Given this list of marker genes FYB1, HOXA11, MPL, SLC7A7, GNA14, ZNFX1, SLC30A7, KIF15, here is a description of the gene set: Human Gene Set: HP_MEGAKARYOCYTOPENIA A reduced count of megakaryocytes. studied in species Homo sapiens Megakaryocytopenia